The following is a description of a gene set: species: Homo sapiens Human Gene Set: CHARAFE_BREAST_CANCER_LUMINAL_VS_MESENCHYMAL_UP from publication Charafe-Jauffret E, Ginestier C, Monville F, Finetti P, Adélaïde J, Cervera N, Fekairi S, Xerri L, Jacquemier J, Birnbaum D, Bertucci F (PMID 16288205) A better molecular characterization of breast cell lines (BCL) may help discover new markers to apply to tumour samples. We performed gene and protein expression profiling of 31 BCL using whole-genome DNA microarrays and immunohistochemistry (IHC) on 'cell microarrays' (CMA), respectively. Global hierarchical clustering discriminated two groups of BCL: group I corresponded to luminal cell lines, group II to basal and mesenchymal cell lines. Correlations with centroids calculated from a published 'intrinsic 500-gene set' assigned 15 cell lines as luminal, eight as basal and four as mesenchymal. A set of genes was differentially expressed between basal and luminal samples. Mesenchymal and basal subtypes were rather similar and discriminated by only genes. The expression of 10 proteins (CAV1, CD44, EGFR, MET, ETS1, GATA3, luminal cytokeratin CK19, basal cytokeratin CK5/6, CD10, and ERM protein moesin) encoded by luminal vs basal discriminator genes confirmed the subtype classification and the validity of the identified markers. Our BCL basal/luminal signature correctly re-classified the published series of tumour samples that originally served to identify the molecular subtypes, suggesting that the identified markers should be useful for tumour classification and might represent promising targets for disease management. Genes up-regulated in luminal-like breast cancer cell lines compared to the mesenchymal-like ones., and this is the list of marker genes: CRIP2, ST6GALNAC2, CRIP1, ARRDC1, ARRDC4, MED28, NHSL3, AP1M2, SYMPK, IDH2, ITPK1, MSX2, CLDN7, ZBTB42, NECTIN4, PPP2R5A, CCDC97, DDI2, TRIM3, GGT6, CREB3L4, HOOK1, EPPK1, RAB17, TRAF4, KLHL28, SSH3, CA12, MPZL3, EPCAM, MRFAP1L2, ALDH6A1, ZBTB7B, PCK2, VPS45, UBQLN4, CRYBG2, SCYL3, ERBB2, SPTBN2, FAM174B, CCDC6, PROM2, SLC7A8, GAREM1, SFI1, NOL3, NEBL, PLCH1, TTC39A, SUN1, BLOC1S1, ST14, H2AJ, MAP7, CD24P4, CBLC, MMEL1, EHF, TMEM276 (transmembrane protein 276), ANK3, SORL1, ACVR1B, TMEM45B, PEX11B, TLE3, H2AC18, SUOX, ZNF74, MLPH, SYNGR1, CYP4B1, PADI2, OCLN, MGMT, ZXDC, ARF3, TMEM268, TRAPPC6A, ISG20L2, MCCC2, RASEF, PLEKHA6, RAB11FIP4, CEACAM6, KDM7A, RHOB, BICDL2, CGN (NCBI Gene Id 57530), CDC42SE1, INPP5J, KATNIP, SEPHS2, CYB5A, TFF1, FANCF, CIRBP, PATZ1, EPS8L1, FCSK, VIPR1, ADCY6, CAMK2N1, SLC29A2, CACNG4, NR2F6, KIFC2 (kinesin family member C2), RAB3D, FGD3, GPD1L (NCBI Gene Id 23171), PAGR1, TMEM125, RGL2, SPINT2, GGCT, ROGDI, KRT19, ADIRF, PGAP2, MUCL1, GSTO2 (glutathione S-transferase omega 2), INHBB, DLG3, EOLA1, MGAT4A (NCBI Gene Id 11320), IQCE, GRHL2, SPDEF, PRRG4, MACC1, ZCCHC8, SERF2, PKP3, AZGP1, SETD6, ARHGEF5, ESRP2, RTL10, CTNND2, KIAA0319L, SYNGR2, S100A8, ELF3, CADPS2, TRIL, SYCP2, TMEM184A, SIDT1, ZNF385A, BLVRB, PLXNB1, C4orf19, JMJD8, SPTLC2, IRF6, MCRIP2, HID1, CLDN4, RMND5B, SH3YL1, SUSD6, SLC44A2, AAGAB, CDH3, GPR160, DBP, TSPAN1, GRAMD4, SPOPL, PDXDC1, RAB27B, PPFIBP2, GSPT1, TFF3, PAQR4, TPD52L1 (NCBI Gene Id 7164), TMED3, TBC1D30 (NCBI Gene Id 23329), PATJ, ERP29, TTC9, TM7SF2, TOX3 (TOX high mobility group box family member 3), HIP1R, FRAT2, TMEM229B, EFNA4, GRHL2-DT, PPDPF, DUSP16, BEX5, MRFAP1L1, OVOL2, ESRP1, VAV3, SYNE4, PRLR, ADGRG1, ARFGAP2, GRHL1, CHMP2A, RBM47, TSPAN13, CYB561, ARFGEF3, NHERF1 (NCBI Gene Id 9368), TADA2B, ZKSCAN1, GATA3 (GATA binding protein 3), OVOL1, TRIB3 (NCBI Gene Id 57761), ANO1, CAPN8, DHRS13, SCAMP2, CHASERR, FBP1, BOLA1, SEMA3F, LYPD3, CHMP4C, SELENOP, CERS6, TOP6BL, ENSA, ANKRD30A, TUFT1, ENPP5, COG7, ATOSA, MINDY1, GALNT6, MB, CACNB3 (NCBI Gene Id 784), TMC4 (NCBI Gene Id 147798), DDR1, P4HTM, USP18, PPP1R16A, PTPN6 (protein tyrosine phosphatase non-receptor type 6), CDH1, EPB41L4A, FEM1B, ESR1, TMEM191A, MIR29B2, EMP2 (NCBI Gene Id 2013), TMEM134, MAL2, BICDL1, SPINT1-AS1, ALDH3B2 (aldehyde dehydrogenase 3 family member B2), TMEM183A, TSC22D3, CNNM4, PCDH1, CACFD1, PLEKHF2, CLN3 (CLN3 lysosomal/endosomal transmembrane protein, battenin), FUT1, FOXA1, TOB1, EXPH5, CASZ1, TP53TG1, FAM83H, MARVELD3, RSPH1, SELENBP1, SLC37A1, PRODH, CHN2, KRT23, EPHB3, SSR4, TMPRSS13, CRABP2, EPB41L5, CRACDL, PRSS8, PPCS, MUC1, ZNF165, PLA2G12A, PER2, NME3, TMEM41A, PDCD4 (NCBI Gene Id 27250), ANXA9, RUSC1, ZHX2, RERG, CLDN3, TMPRSS2, ASB8, MYLIP, TSTD1, SMPDL3B, WFS1, PRKD2, RIPOR3, SLC16A14, SOX13, CKMT1B, ERBB3, COP1, RAB40C, PRR15, NPDC1, SERINC2, FA2H, RAB25, GPR157, FLAD1, SH2D3A, RAB5B (RAB5B, member RAS oncogene family), MYO5C, PRR15L, BLNK, SUCO, SSBP2, MYO6, TNKS1BP1, TMEM30B, SEMA4A, CAMSAP3, LSR, MYB, FAM110A, MKNK2, MARVELD2, MRPL41, EPN3, CEBPA, CD24P2, TJP3, FREM2, GRB7, DENND2D, AGR2 (anterior gradient 2, protein disulphide isomerase family member), SULT2B1, TMBIM4, S100P (S100 calcium binding protein P, NCBI Gene Id 6286), TNK2, STARD10, DHRS4-AS1, S100A14, COMMD3, DEGS2, BSPRY, PIP4K2C, SIGIRR, TENT5C, C1orf43, TC2N, PWWP2B, ZNF24, DNAJC1, TMBIM6, MPP7, LIMK2, HILPDA, LAD1, PLXNA3, ICA1, CSAD, GOLT1A, VRK3, ARHGAP8, BBIP1, ENTPD2, ELAPOR1, PREX1, PPM1H, EEIG1, JUP, TMEM79, MREG, RHOH, ENSG00000280119, TMT1A, DCAF11, ZG16B, LMTK3, MYO1D, FKBP4, EPHA1, MCF2L, RHPN1, BCAS1, C6orf132 (NCBI Gene Id 652183), ULK1, JTB, MEGF9, BCR (NCBI Gene Id 729775), FXYD3 (FXYD domain containing ion transport regulator 3), SYT7, FAAH, IRX5, ABCC11, ANKRD22, SLC52A3, CD24, APH1A, TRPS1, IGFBP2, ULK3, MYH14, PPP1R3D, DAAM1, CDS1, RHBDF1, KIAA0040 (NCBI Gene Id 9674), TMEM241, SLC25A29, ABHD11, ELMO3, SPATA2L (spermatogenesis associated 2 like), TRPM4, HOOK2, ELL3, DNAJA4, EFHD1, C11orf52, BIK, RPS6KA5, PGAP3, RABEP2, RNF103, ABAT, ALDH4A1, ATP6AP1, SYTL1, SLC35A1, ABCA12, GPR89B, REEP5, F11R, DOK7, CACNA1D, SHANK2, RALGPS1, IFT20, LLGL2, ABCG1, SPINT1, ARFIP2, MYO5B, ZNF467, LNX1, ATP2C2, RNF144B, DSCAM-AS1, C9orf152, CRNDE